Given this list of marker genes ZDHHC2, CAV1, UMOD, MYADM, RFTN1, FLOT2, CD24, CYP46A1, REEP2, ATP1B1, here is a description of the gene set: A process in which a protein is transported to, or maintained in, a location within a membrane raft. studied in species Homo sapiens Human Gene Set: GOBP_PROTEIN_LOCALIZATION_TO_MEMBRANE_RAFT